The following is a description of a gene set: Human Gene Set: MIR128_2_5P Genes predicted to be targets of miRBase v22 microRNA hsa-miR-128-2-5p in miRDB v6.0 with MirTarget v4 prediction scores > 80 (high confidence targets). from publication Chen Y, Wang X (PMID 31504780) species: Homo sapiens, and this is the list of marker genes: DUSP8 (NCBI Gene Id 1850), IQSEC2 (IQ motif and Sec7 domain ArfGEF 2), TMED7-TICAM2, NRM, TBC1D25, RHOA, SDK1, CDH15, IQSEC3, TMEM86B, CBFA2T3, GNG13, SUGP2